Given this list of marker genes SIM1, PDZK1IP1, CDIP1, BICRAL, FOXJ2, PLAG1, TMEM239, SF3B2, HECTD4, CACNB1, ZNF148, CTNND1, PLEKHH3, ADIPOR2, GMCL1, ERV3-1, JADE1, KSR1, CSDE1, ANKRD24, WASHC4, VDAC1, RNF180, ABCA1 (ATP binding cassette subfamily A member 1), MTCL2, CGGBP1, TRIL, CEBPZOS, UBQLN2, SFPQ, FMN1, TNIK, RAB1B, CA14, DARS1, TSHZ2, PLEKHA1, ZNF521, ADPRM, CHD8, PRICKLE1, NALF2, RAD9B, CENPB, LAMA5, CBX5, here is a description of the gene set: from publication Chen Y, Wang X (PMID 31504780) Human Gene Set: MIR6895_5P species: Homo sapiens Genes predicted to be targets of miRBase v22 microRNA hsa-miR-6895-5p in miRDB v6.0 with MirTarget v4 prediction scores > 80 (high confidence targets).